The following is a description of a gene set: Mouse Gene Set: GOBP_REGULATION_PROTEIN_CATABOLIC_PROCESS_AT_SYNAPSE Any process that modulates the frequency, rate or extent of the chemical reactions and pathways resulting in the breakdown of a protein at the synapse. species: Mus musculus, and this is the list of marker genes: Nedd4l, Vhl, Prkn, Usp5, Trim3 (tripartite motif-containing 3), Plekhg5, Cul3, Rab26, Klhl17, Cblb, Pin1, Egln1, Ube2n, Nedd4